The following is a description of a gene set: Genes down-regulated in bone marrow-derived macrophagesat 180 min stimulation by LPS: IL6 knockout versus IL10 knockout. Human Gene Set: GSE5589_IL6_KO_VS_IL10_KO_LPS_STIM_MACROPHAGE_180MIN_DN IL-10 or IL-6 stimulation of control 129xC57BL/6 murine bone marrow derived macrophages in the presence of LPS. We used microarrays to detail the global programme of gene expression changes in response to IL-6 or IL-10 stimulation in the presence of lipopolysaccharide. BMDMs were isolated from control, IL-6-/-, and IL-10-/- mice on a 129XBL/6 mixed background mice and differentiated in the presence of CSF-1 for 6-7 days. Cells were scraped and plated in 6 well plates at 2x10e6/well. Cells were washed with complete DMEM and rested for 1-2 hr before stimulation with combinations of IL-10 (10 ng/ml), IL-6 (2 ng/ml) or LPS (100 ng/ml) for 45 min or 180 mins. Complete biological replicates were performed. from publication El Kasmi KC, Holst J, Coffre M, Mielke L, de Pauw A, Lhocine N, Smith AM, Rutschman R, Kaushal D, Shen Y, Suda T, Donnelly RP, Myers MG Jr, Alexander W, Vignali DA, Watowich SS, Ernst M, Hilton DJ, Murray PJ (PMID 17114459) species: Homo sapiens, and this is the list of marker genes: TBX15, STK11IP, SOX13, FCGR3A, PGAP3, GP1BB, S100A5, NECTIN4, TPBG (NCBI Gene Id 7162), SLC32A1, INPP5D, PITPNM1, SNCA, APOBEC1, CTDSP1, ANO3 (NCBI Gene Id 63982), BAIAP2, ENGASE, SH3BGR, SORD, GPR137B, AP2A2, SP4, PLIN2, PRKCI (NCBI Gene Id 5584), IGSF23, IDNK, ARHGAP19, ANKRD33B, TMEM260, MED29, C5AR1, CDHR4, FRAT2, FAM86B2, PPP1CA, SMPDL3A, STAG3, AIF1, KRT7, RNASEH2C, ZNF512B, ITGB5, NALF1, GALNT15, ECI1, PEG10, ARMC2, GSTT2, ORM2, CIAO3, GAK, ABCB10 (NCBI Gene Id 23456), CRIP3, SOX2-OT, HNRNPLL, NATD1 (N-acetyltransferase domain containing 1), DDX24, RRP36 (ribosomal RNA processing 36), PROM1, RBP1 (retinol binding protein 1), GUK1, ITM2B, ABHD3, MIR1915HG, LDB1, PPARA, GDPD1, ZNF251, BCL2L11, FAM219B (family with sequence similarity 219 member B), SLC30A1 (solute carrier family 30 member 1), SSBP4, SLC40A1, TBC1D22A, NEDD8, APH1B, PIK3R3, EIF2A, TMT1A (NCBI Gene Id 25840), MFAP3L (microfibril associated protein 3 like), MPEG1, DEPDC7, AXIN1, SNX5, PIK3R5, TRIM25, RHOH, TBC1D8, DNAJC4, CNP, LGALS4, SNORD123, GUCD1, SUPT5H, NLRP5, AGPAT3, SIX6, TSLP, PARP9, PRKCD, F8, FSD2, DYNLT1, B3GNT2, B3GALT5, POLR2J, SUSD1, GDPD3, DXO, STARD3, APOC2, CD46, SNIP1, CD300A, FAM83F, ACOT1, ACTB, RAD9A, SLC11A1, BRINP1, TALDO1, ACOX1, REC8, GDF15, SHPK, SULT6B1, UCP3, RNF181, PCP4, C11orf54, CES3, RALGDS, ANGPTL4, HPS6, NME4, SOD1, PON3, RASA3, LGMN (legumain), CREG1, ELFN2, TPRA1, IFT52, TOP3A, SCD, SLC41A3, SH2D1B, CIPC, POU6F2, HMOX1, ACP5, NUAK2, FCGR2A, ART5, CHRDL2, CPSF4, PIAS2, SPAG6, TMUB1, AUP1, CLCA2, ASB4, NT5C3B, SERP1, LY9, LYSMD2, MRPS6, PLA2G15, OSBPL10, SNX9, KCNC2, NHSL3, SELENBP1, HMOX2, TMEM140, HBA2 (hemoglobin subunit alpha 2), COX20, PGLS, GABARAPL1, GPC2, ADIPOQ, UQCC1, TST, GPR161, PSAP, CSF2, OTULINL, PLPPR5, BBOX1, ABI3, PNPLA7, SOX9, BHLHE23, REG1B, SUCNR1, NEDD4, MAB21L1, SLC38A3, TMBIM6